The following is a description of a gene set: Mouse Gene Set: GOMF_SPECTRIN_BINDING species: Mus musculus Binding to spectrin, a protein that is the major constituent of the erythrocyte cytoskeletal network. It associates with band 4.1 (see band protein) and actin to form the cytoskeletal superstructure of the erythrocyte plasma membrane. It is composed of nonhomologous chains, alpha and beta, which aggregate side-to-side in an antiparallel fashion to form dimers, tetramers, and higher polymers., and this is the list of marker genes: Myo10, Ank3, Kif3a, Sptbn5, Ptprn, Dmtn, Ank2, Myo7a, Sptbn4 (spectrin beta, non-erythrocytic 4), Dync1i1, Ush1c, Gnb1, Gbp2, Gbp2b, Gnb3, Camsap3, Slc26a5, Add1, Epb41, Unc13a, Camsap2, Epb41l2, Pde6g, Ank1, Sptan1, Ush1g, Camsap1, Nphs1, Dctn2, Add2, Ptprc, Rho, Sag